The following is a description of a gene set: species: Homo sapiens Human Gene Set: REACTOME_NEGATIVE_REGULATION_OF_FGFR2_SIGNALING Negative regulation of FGFR2 signaling, and this is the list of marker genes: SRC, FGF6, FGF18, FGF17, CBL, PPP2CA, FRS2, BRAF, FGFR2, FGF1, MKNK1, PPP2R1A, FGF7, MAPK3, FGF16, SPRY2, UBA52, FGF10, FGF22, FGF3, FGF9 (fibroblast growth factor 9), FGF23, MAPK1, FGF8, RPS27A, FGF5, GRB2, UBB, FGF4, FGF20, PTPN11, FGF2, UBC, PPP2CB (NCBI Gene Id 5516)